Given this list of marker genes SCN4A, SPTAN1, GNS, MEGF10, NGLY1, SLC39A14, LMNA, POMT1, ABCC9, PYROXD1, MTMR14, ADAT3, ZC4H2, LMX1B, SYNE1, COL6A1, LARGE1, TMEM43, NSUN2, PTRH2, CRPPA, SGCA, MYOT, PLEC, ACTA1, DMD, UFC1, KY, JAG2, MT-TE, FHL1, BICD2, ALS2, DNM2, MARS1, SLC25A4, COL6A3, GJB1, COL12A1, ABHD12, TNNT1, SLC12A6, OPA1, FKTN, SYNE2, TTN, EMD, SGCG, HINT1, COL6A2, FKRP, HRAS, PLAAT3, ADAMTS15, here is a description of the gene set: Human Gene Set: HP_ACHILLES_TENDON_CONTRACTURE Achilles tendon contracture A contracture of the Achilles tendon. species: Homo sapiens